Given this list of marker genes Pkd1, Atp4a, Akt1, Nfatc1, Scn10a, Nipa2, Jph2, Glra4, Nipsnap2, Coa8, Glrb, Fgf12, Gabrd, Kcnq3, Slc12a4, Kcnh7, Kcne1, Panx3, Slc39a13, Casq2, Slc5a1, Romo1, Htt, Slc18b1, Slc24a2, Cxcl12, Itpripl1, Steap4, Ramp3, Serpine1, Rapgef3, Slc38a5, Pkd2 (polycystin 2, transient receptor potential cation channel), Cacna1i, Slc6a3, Abl1, Ndufv2, Ano6, Arrb2, Nmur1, Gp1bb, Kcnk10 (potassium channel, subfamily K, member 10), Neto1, Add2, Ttyh2, Clca3a1, Rgs9, Cnksr3, Atp2a3, Arf1, Ucp3, Cdk5, Fkbp1b, Slc6a20b, Vamp2, Ppp3cb, Cntn1, Trpv5, Htr3b, Klhl3, Asph, Clca1, Wwp2, Atp13a4, Gal, Cacng8, Fkbp4, Oga, Plcb4, P2rx3, Mllt3, Capn3 (NCBI Gene Id 98918), Hoxa3, Grp (NCBI Gene Id 225642), Slc38a7, Nppa, Fyn, Micu1, Apol11a, Gabrp, Xcr1, Mfsd5, Atp6v0a1, Atp8b1, Ripk1, Fxyd1, Ednrb, Nos1, Akap5, Kcnma1, Ndufa2, Snta1 (syntrophin, acidic 1), Efhb (EF hand domain family, member B), Ccl12, Stac, Cblif, Slc6a16, Reln, Nsf, Mmp9, Atp5f1e, Sik1, Tomm40l, Atp1a1, Smim6, G6pdx, Kcnf1, Il16, Gria3, Atp6v0d1, Slco1c1, Gpr39, Scnn1b, Ywhah, Slc1a7, mt-Atp6, Tmem163, Hephl1, Atp2a2, Iscu, Arhgap1, Prss30 (serine protease 30), Slco2b1, Sco1, Trem2, Selenon, Gabrg2, Nos3, Letm2, Atp2c2, Kcnk3, Gabrb1 (NCBI Gene Id 320243), Gabra3, Atox1, Scn8a, Tgfb1, Ryr1, mt-Nd2 (NCBI Gene Id 99241), Pkd2l1, Mylk, Ccl19-ps5, Casq1, Plce1, Slc36a2, Plch2, Kcnip3, Kcnq2, Vdac3, Sfxn3, Atp6v1g1, Mettl21c, Mt3, Prkd1, Ppp3cc, Kcnj2, Sfxn1, Slc9a8 (NCBI Gene Id 98868), Slc22a17, Otop2, P2rx7, Gria1, Chrna6, Atp1b4, Slc8a2, Slc1a3, Kcnc4, Gpd1l, Akt2, Micu3, Plcg2, Cxcl11, Slc1a2, Bax, Tmem165, Mfsd4b1, Slc25a14, Sln, Lime1, Cav3, Kcnh2, Lrrc38, Glp1r, Ace, Mcoln1, Lck, Lep, Slc13a1, mt-Co2, Actn2, Cox17, Slc24a5, mt-Nd1, Trpm8, Edn1, Sfxn5, Bpifa5, Oca2, Ywhaq, Kcnn1, Kcns2, Kcnn4, Prkcb, Epo, Trpa1, Ramp1, Slc25a12, Sfxn2, Trpc4, Kcna6 (NCBI Gene Id 16494), P2ry1, Cldn10, Ostm1, Slc9a1, Slc6a17, Slc5a5, Rcvrn, Ano3, Slc41a3, Slc26a7, Atp6v1g2, Plcg1, Drd2, Lrrc52, Pgrmc2, Ptk2b, Slc4a8, Scn7a, Slco4a1, Kcna2, Prss8, Kcnip4, Tsc1, Rnf207, P2rx2, P2rx6, Kcnn2, Slc30a2, Adrb2, Ndufv1, Slc38a11, Piezo2, Slc9a9, Ubash3b, Slc13a2, Slc17a6, Kcnj1, Pllp, Clcn7, Nr3c2, Ptpn22, Bsnd, Ccn2, Kcnmb4, Slc22a5, Kel, Fth1, Mchr1, Chrna3, Slc30a6, Slc9b1, Mmgt2 (NCBI Gene Id 216829), Bspry, Abcb6, Ppp3ca, Mcur1, Stk39, Fxyd3, Tmem63b, Cysltr1, Slc10a4, Kcnab3, Kcnj15, Mcoln3, Kcne3, Amigo1, Lcn2, Gnaq, Nfatc3, Ano7, Slc10a2, Oprd1, Slco4c1, Atp2b2, Cacna1h, Aqp1, Plcz1, Ubr3, Slc46a3, Scn3a, Gjd3, Chrna9, Gnai2, Cd4, Gnb5, Ctnnb1, Fgf13, Plcl1, Slc11a2, Hcn2, Atf4, Bin1, Slc26a8, Timd2, Nipal4, Psen2 (presenilin 2), Gabrg3, Slc4a10, Edn3, Ano4, Ttyh3, Htr2b, Cracr2b, Fbxo11, Atp2a1, Slc22a21, Gabrq, Tmco3, Cldn17, Slc6a11, Slc22a1, Trf, Tlr9, Dhrs7c, Slc39a11, Slc6a5, Tpcn2, Clec4b1, Gstm7, Scn2a, Nherf1, Best2, Kcnv1, Slc30a8, Hpca, Pde4d, Slc39a4, Ehd3, Itgb1, Gabra6, Pdgfb, Slc12a5, Plcl2, Homer1, Slc26a11, Nipal2, Akap9 (NCBI Gene Id 97235), Catsper4, Tusc3, Aqp2, Otop1 (otopetrin 1), Slc6a9, Gp5, Gabra5, Sgk1, Grin1, Slc26a1, Gabrb3, Ndufa4, Atp5mf, Slc18a1, Glra1, Ahnak, Serpine2, Atp5mg, Trpv3, Casr, Slc5a2, Zfas1, Cxcl1, Slc20a1, Calhm6, Gpm6a, Chrna5, Slc48a1, Atp1a4, Kcnj16, Trpm7, Cyp27b1, Slc25a3, Slc25a13, Wnk1, G6pd2, Ucp1, Atp6v0c, Inpp5k, Slco1a4, Slc20a2, Clcn4, P2ry6, Gria2, Cacna1f, Otop3, Kcnh1, P2ry12, Stc1, Prkg2, Abcc8, Ndufs1, Kcnd3, Orai1, Atp1b3, Chrne, Gpr35, Cask, Chrm5, Kcnk2, Ywhae, Cxcr4, Cyba, Trdn, Hbp1, Atp5f1c, Pacc1, Slc25a22, Cnnm4, Gabra1, Scnn1g, Hamp, Psen1 (presenilin 1), Slc6a8, Slc16a1, Slc34a3, Bdkrb1, Cacng6, Ank3, Grik4, Ppif, Chrnd, Slc22a23, Tpcn1, Slc5a8, Zdhhc13, Tmem150c, Sumo1, Hspa9, Fxn, Slc4a11, Slc31a1, Adcyap1r1, Slc25a28, Slc45a4, Pxk, Slc6a21, Slc11a1, Cacna1g, B2m, Nalf2, Grid1, Ncs1, Hcn3, Chrna2, Per1, Cd19, Atp6v1e1, Kcnj11, Trpv6, Atp5me, Tg, Slc47a2, Slc25a23 (NCBI Gene Id 66972), Cdh23, Slc41a1, Cacnb2, Sestd1, Ffar1, Ano10, Ptpn6, Cacna2d3, Slc4a7, Ndufa10, Ucp2, Uqcrh, Chrng, Phb2, Ccl21a, Slc9c1, Abcc9, Homer3, Pik3cg, Kcnc2, Mrln, Clic3, Calhm2, Tgfb2, Slc38a2, Slc5a4b, Thy1, Grin3a, Tmc2, Dspp, Slc6a6, Tcaf1, Nalcn, Calhm3, Tmem120a, Lrrc26, Hsd3b3, Atp5pb, Gabrr2, Clca4a, Clcn6, Commd1 (COMM domain containing 1), Slco1b2, mt-Co1, Slc4a1, Commd9, Tmem63c, Slc4a2, Akap6, Osr1, Alg10b, Scara5, Ifng, Pik3c2a, Il4, Atp5mc2, Slc26a5, Bpifa1, Cnga3, Clcn2, Ppp3r2, Atp5po (ATP synthase peripheral stalk subunit OSCP), Agtr1a (NCBI Gene Id 72294), Creb3, Cacng2 (calcium channel, voltage-dependent, gamma subunit 2), Cckar, Epb41, Slc31a2, Nherf2, Dbi, Trpm3, Nalf1, Slc6a12, Wnk3, Ano8, Trpv2, Smdt1, Kcne4, Chrm1, Kcna1, Prnp, Cdk2, Ano5, Best1, Hvcn1, Scn1a (sodium channel, voltage-gated, type I, alpha), Chrna7, Kcna5, Slc22a2, Cacna1e, Ms4a1, Slc10a7 (NCBI Gene Id 76775), Kcnip1, Bhlha15, Slc26a9, Slc26a3, Zmpste24, Atp6v1g3, Cacna2d1, Dpp10, Kcnq5, Usp2, Clcnka, Chrna4, Tmem175, Jak3, Atp6v1a, Lrrc55, Akt3, Slc23a2, Cox7a1, Rab11b, Camk2d, Cnga1, Cherp, Slc9a3, Kcnh6, Cacna2d4 (calcium channel, voltage-dependent, alpha 2/delta subunit 4), Adcyap1, Kcnj3, Wnk4, Cacnb4, Fxyd4, Slc6a19, Commd3, Slc9a6, Scn5a, Cxcl9, Slc9a7, Hrh1, Fasl, Scn4b, Dmd, Chrnb4, Ccl5, Ptprc, Kcnd1, Adora2a, Grin2d, Hrc, Vip, Slc26a2, Rnasek, Camk2b (NCBI Gene Id 12323), Tescl (tescalcin-like), Fcrl5, Atpsckmt, Gja4, Kcnmb1, Spg7, mt-Nd4, Slc38a1, Cacng7, Flna, Trpm5, Strit1 (NCBI Gene Id 102637511), Atp7a, Slc18a3, Hpn, Gcm2, Slc22a20, Dmpk, Tmco1, Slc4a5, Prkce, Chp1 (calcineurin-like EF hand protein 1), Slc13a3, Chd7, Gas6, Pkd1l1, Cd84, Asic2, Slc15a1, Cnga2, Tcn2, Fxyd7, Slc9a4, Kcnj14, Magt1, Wfdc6a, Slc30a9, Ltf, Maob, Slc25a4, Mlc1, Ero1a, Anxa6 (annexin A6), Atp13a2, Ubqln1, Atp2b4, Tfrc, Panx1, Grin3b, Tmc4, Hes1, Ftl1, Kcnt1, Clca2, Slc38a3, Abcc5, Coro1a, Slc30a3, Vmp1, Slc28a3, Slc34a1, Sphk2, Kcnmb2, Nmur2, Atp5pf, mt-Cytb, Kcnn3, Kcnip2, Racgap1, Atp6v1e2, Kcnt2, Large1, Cldn15, Wnt3a, Calm2, Fthl17e, Guca2b, Kcnh8 (potassium voltage-gated channel, subfamily H (eag-related), member 8), Calhm1, Drd3, Ccl19-ps3, Slco1a1, Ddit3, Slc22a3, Gm5134, Ndufs2, Slc26a6 (solute carrier family 26, member 6), Hrh3, Gabra4, Slc22a16, Cacnb1, Cacng3, Drd1, Clcn3, Ptgs2, Slc17a8, Kcnj5, Orai2 (NCBI Gene Id 677007), Itpr3, Cyc1, C2cd6, Cybb, Steap1, Cx3cl1, Atp5mc1, Vps4b, Scn11a, Nectin1, Grin2b, Slc39a1, Slc5a3, Slc5a7, Gnb2, F2rl3, Atp12a, Slc1a4, Ahcyl1, Jph4, Plcb2, Grm6, Gabrb2, Trpm2, Cxcl10, Lilra5, Ramp2, mt-Nd5, Cd300a, Trpm1, Gper1, Cnnm2, Ndufb7, Slc22a18, Sri, Kcnk9, Slc39a3, Stim2, Kcnq1, Dlg1, Trpc3, Pml, Clcnkb, Atp5f1d, Gp1ba, Trpv4, Taco1, Rem1, Slc39a8, Adra1a, Clic4, Tmem37, Cdkn1b, Ibtk, Slc4a9, Dnm2, Atp1b2, Tmem109, Slc18a2, Ndufs4, Cd63, Trpv1, Stac3, Pdgfrb, Tacr2, Abcc3, Tspan13, Ndufs8, Slc5a9, Aqp6, Slco1a5 (solute carrier organic anion transporter family, member 1a5), Atp6v1h, Clic1, Kcnj8, Ucn, Slco3a1, Cldn4, Slc12a3 (NCBI Gene Id 20497), Tmem38b, Slc6a7, Camk2a, Cltc, Itpr1, Slc36a3, Myo1b, Pcsk9, Cnga4, Hcrt, Oprk1, Slc6a13, mt-Nd4l, Trpm4, Spink1, Opa1, Clca3a2, P2rx1, Lpar3, Kcnk7, Pkd1l3, Slc12a2, Gjc2, Ano1, Bmp4, Abcb1a, Kcnj9, Srl, Slc12a9, Ano2, Atp6v1b2, Drd4, Cox4i2, Ptger3, Mllt6 (myeloid/lymphoid or mixed-lineage leukemia; translocated to, 6), Slc26a10, Fgf2, Slc22a12, Hfe, Agrn, Itgav, Clic5, Rep15, Kcnc1, Slc15a2, Kcna7, Slc30a5, Slc10a5, Catsper3, Diaph1, Fxyd2, Isl1, Atp5f1a, Slc5a6 (solute carrier family 5 (sodium-dependent vitamin transporter), member 6), Umod, Vdac2, Slc30a4, Gck, Gimap3, Lrrc8b, Kcnk13, Chrna10, Hspa2, Atp6v0b, Slc22a7, F2r, Atp10d, Slc22a22, Crhr2, Camk2g, Hif1a, S100a6, Gsto1, Slc1a1, Itpr2, Ghitm, Slc9a5, Slc25a18 (NCBI Gene Id 71803), Sptbn4, Slc6a14, Dot1l, Lhcgr, Ccl19-ps6, Scn9a, Galr2, Pawr, Tspo, Fmr1, Kcnk12, Slc5a10, Steap2, Gja1, P2ry4, Atp6v0d2, Kcnrg, Ccr1, Fxyd5, Slc22a8, Slc17a1, Slc6a15, Wnk2, Lhfpl5, Kcng3, Slc38a4, Dpp6, Slc8a3, Car2, Kcna4, Kcna10, Nipa1, Slc17a2, Hcn4, Tomm40, Slc23a1, Atp6v0a2 (ATPase, H+ transporting, lysosomal V0 subunit A2), Slc9b2, Atp6v1c1, Atp2b3, Kcng1, Ryr2, Cngb3, Ccl19-ps1, Atp1b1, Slc15a4, Cacna1c, Kcnc3, Slc41a2, Il13, Kcnj12, Pacsin3, Calm3, Cacna1b, Plch1, Npsr1, Slc17a4, Scnn1a, Slc46a1, Atp6v0e, Kcnk15, Asic5, Kcns3, Slc39a6, Cxcr3, Sting1, Calcrl, Kcnab2, Lyn, Kcnj6, Kcnb1, Eppin, Slc40a1, Slc30a10, Rgs7 (NCBI Gene Id 24012), Grxcr1, Lasp1, Slc8b1 (solute carrier family 8 (sodium/lithium/calcium exchanger), member B1), Nkain2, Slc6a18, Sec61a1, Hsd3b2, Tcirg1, Afg3l2, Nedd4, Steap3, Tmem94, Abcc2, Surf1, Ndufs3, Epm2a, Gabre, Slc12a7, Cracr2a, Slc45a3, Snca, Grik5, Snap25, Asic3, Atp6v1f, Plpp4, Spg11, Jsrp1, Cbarp, Maip1, Ngf, Tmem74, Lgals3, Piezo1, Pkd2l2, Ahr, Ccl19, Kcnk5, mt-Nd3, Slco1a6, Atp6v1b1, Myo5a, Chp2, Atp6v0a4, Chrnb3, Ndfip1, Gpr89, Kcnj10, Scn3b, Gcg, Gm13629, Atp6v1d, Grin2a, Scn2b, Htr1b, Slc22a19, Abcb1b, Cacna1d, Kcnj13, Maged2, Asic1, Kif5b, Slc25a5, Ntsr1, Abcb7, Hamp2 (NCBI Gene Id 66438, hepcidin antimicrobial peptide 2), Slc47a1, Cngb1, Scn1b, Igf1, Slc30a7, Stc2, Gp9 (glycoprotein 9 platelet), Slc5a12, Kcna3, Gabrg1, Slc22a4, Adora1, Egf, Htr1a, Best3, Heph, Snx3, Gopc, Nedd4l, Slc39a2, Kcns1, Mrs2, Gnas, Ryr3, Slc6a20a, Grm7, Ms4a2, Slc13a5, Slc10a6, Ccl21f, Mcub, Kcne2, Nkx2-5, Tmc1, Slc30a1, Tmx1, Clcc1, Htr2a, Nkain3 (Na+/K+ transporting ATPase interacting 3), Cachd1, Rangrf, Inhca, Trpc5 (transient receptor potential cation channel, subfamily C, member 5), Kcnk18, Lrrc8d, Glra2 (NCBI Gene Id 237213), Catsper1, Cacng5 (calcium channel, voltage-dependent, gamma subunit 5), Pon3, mt-Co3, Clic6, Kcng2 (NCBI Gene Id 240444), Slco1a8, Rgs4, Htr2c, Micu2, Cnnm3, Trim27, Slc32a1, Hpx, Plcb1, Ap3d1, Ccl21e, Cftr, Icam1, Kcnv2, Slc9a2, Ikbkb, Abcb8, Lmtk2, Slc12a1, Kcnk4, Kcnk1, Crbn, Grik1, Slc6a2, Trpm6, Cacna2d2, Bcl2, Hcn1, Calhm4, Slc26a4, Nkain1, Ndufs7, Flvcr1, Calm1, Tesc, Lrp2, Ttyh1, Slc25a27, Homer2, Cemip, Ank2, Pirt, Mcu, Tmem63a, Stimate, Cldn16, Gabrr3, Slmap, Slc45a1, Atp5pd, Cacnb3, Lrrc8c, Bak1, Slc39a12, Kcng4, Atp6ap2, Tmem168, Slc22a15, Slc4a3, Slc29a4, Uqcrfs1, Slc36a1, Wfs1, Gabra2, Orai3, Pdpk1, Pln, Ftmt, Grik3, Ptpn3, Grid2, Slc6a1, mt-Nd6, Kcnq4, Grin2c, Cnnm1, Gnao1, Chrna1, Slc24a4, Slc39a5, Htr3a, Oxsr1, Atp6v1c2, Cpox, Trpc2, Trpc7, Kcnb2, Kcnk6, Atp1a3, Clns1a, Slc24a3, Slc19a1 (solute carrier family 19 (folate transporter), member 1), Kcnu1, Grik2, Tmem266 (transmembrane protein 266), Mmgt1, Kcnh5, Atp6ap1, Ccl3, Glra3, Atp13a5, Trpc1, Fhl1, Vdr, P2rx5, Slc17a7, mt-Atp8, Kcnab1, Fxyd6, Ednra, Aplnr, Slc4a4, Htr7, Tmbim6 (NCBI Gene Id 68309), Ccl21d, Fgf14, Scn4a, Slc6a4, Slc39a10, Nipal1, Pcyox1, Atp5mc3, Slc24a1, Nlgn3, Stac2, Ano9, Ccl21b, Kcnh4, Slc5a4a, Kcnd2, Cacng4, Slc39a7, Gramd2a, Slc34a2, Lrrc8a, Slc10a1, Ctss, Ccl8, Nkain4, Gimap5, Atp2b1, Cacng1, Chrnb2, Cav1, Stom, Atp13a3, Slc25a37, Mtor, Kcnk16, Crh, Mfsd8, Clcn5, Slc8a1, Panx2, Slc5a11, Akap7, Hap1, Kcnmb3, Atp7b, Letm1, Atp2c1, Asic4, Flvcr2, Nipal3, Slc12a6 (NCBI Gene Id 93718), Ppp3r1, Atp4b, Nnt, Plp1, Itgb3, Adrb1, Catsper2, Nol3, Ccr1l1, Slc35g1, Gria4, Kcnh3, Ctns, P2rx4, Cnr1, Ccl19-ps4, Atp5f1b, Dysf, Slc25a25, Slc45a2, Stim1, Trpc6, Rhoa, Selenok, Dnm1l, Saraf, Tfr2, Chrnb1, Ccdc51, Mcoln2, Atp1a2, Tspan18, Dmac2l, Gjc1, Clcn1, Plcb3, Pdzk1, Meltf, Lrrc8e, Kcne5, Atp6v0e2, Myb, Cacna1s, Jph3, Gja5, Gabrr1, Il6, Car7, Slc39a9, Xcl1, Agt, Hsd3b6 (NCBI Gene Id 97113), Cacna1a, Tmem38a, Kcnj4, Sfxn4, Vdac1, Fkbp1a, 1810037I17Rik, Calhm5, Atg5, Slc12a8, Ccr5, Slc39a14, Slc22a6, F2, here is a description of the gene set: The directed movement of a monoatomic ion into, out of or within a cell, or between cells, by means of some agent such as a transporter or pore. Monatomic ions (also called simple ions) are ions consisting of exactly one atom. Mouse Gene Set: GOBP_MONOATOMIC_ION_TRANSPORT studied in species Mus musculus